Given this list of marker genes DDX11, IVL, KLK7, CEP131 (NCBI Gene Id 22994), H19, SLPI, MYZAP, KRT78, PLBD1, PALMD, RMI2, VSIG10L, MIR1915HG, FAM25A, DEGS2, KRT24, PRRT3-AS1, CEP68, TEDC1, RAPGEFL1, ANPEP, HES5, FAM117A, IGFL1, PLLP, CALML5, WDR62, EPN3, S100A7, CCDC88B, FOXRED2, LRRC45, ECM1, HERC2P2, KLK11, HOPX, BNIPL (BCL2 interacting protein like), KIFC2, NCCRP1, PADI1, CRCT1, ABHD14A, ZNF608, TCN1, CRABP2, TENT5B, HEY1, NGEF, ADAMTSL4, LY6D, ZNF467, PGLYRP4, SOX6, DHRS9, CYSRT1, ARHGEF4, SBSN, EPHA4, RPTN, CWH43, KCP, FAM238C, DDX12P, RHOBTB1, HROB, OSR1, EPB41L3, ALDH3B2, TBC1D8, ANKRD22, TRIM45, RFX2, RCOR2 (REST corepressor 2), TEDC2, SERPINB3, TMEM45B, TMPRSS13, CAPN14, CBX2, DGAT2, PRICKLE2, SULT2B1, SMO, FZD2, ANKRD35, TUBAL3, TMEM184A, LURAP1L, E2F8, KLK13, TGFB3, ZSCAN31 (NCBI Gene Id 91921), RBBP8NL, SPRR1A, CSTA (cystatin A), RNF208, WDR90, EPHB3, TMEM86A, DBP, LCE3D, RHCG, NECTIN4, DDX12B, GUCY1A1, HPGD, NLRX1, PLXNB3, ENSG00000205890, C21orf58, MAB21L4, KLK10, RHOV, RASL11B, EPHX3, SH3BP5-AS1, PPFIBP2, GRHL3, SLC43A2, MIR600HG, ATP6V1E2, LRRC20, ANXA9, CEACAM5, GSEC, CASTOR1, VAV3, S100A9, A2ML1, MUTYH, PHLDB3, CLCA4 (NCBI Gene Id 22802), SCNN1B, SERF2, EFNA4, S100A12, ADM5, SPINK5, CEBPA-DT, CES3, SPRR3, AIF1L, CEBPA (NCBI Gene Id 1050), ZNF862, LINC01559, PLA2G4E, PLA2G6, CSTB, RAP1GAP, SLC25A27, NBEAL2, EVPL, VGLL1, SYT8, KMT5C, EFNA3, RARB, CCDC78, SPINK7, ARHGAP33, ANO8, SYTL1, EFS, IFITM10, KLK8 (kallikrein related peptidase 8), FAM86B3P, ITGB7, LUARIS, CTSV, KALRN, AQP3, TJP3, S100A8, AATBC, PRR15L, MVK, LYNX1, GDPD3, ATP12A, SPRR1B, CARD14, SLC37A2, PPP1R3C, FAM86C1P, ANKRD18A, CHTF18, IRAG2, HYAL1, NOXA1, KRT16, CXXC5, E2F1, EME1, C15orf62, BICDL2, JMJD7, THAP8, CALB1, RASAL1, CNKSR3, MEIS1, MZF1, VWF, PRSS27, CNFN, LYPD3, ZNF692, SIX5, UNC13D, FBF1, LMCD1, COQ8A, KLK12, PLA2G4F, PLEKHH3, MUC21 (mucin 21, cell surface associated), IDI2-AS1, here is a description of the gene set: from publication Blanco-Melo D, Nilsson-Payant BE, Liu WC, Uhl S, Hoagland D, Møller R, Jordan TX, Oishi K, Panis M, Sachs D, Wang TT, Schwartz RE, Lim JK, Albrecht RA, tenOever BR (PMID 32416070) Human Gene Set: BLANCO_MELO_BETA_INTERFERON_TREATED_BRONCHIAL_EPITHELIAL_CELLS_DN studied in species Homo sapiens Genes down-regulated on treatment of normal human bronchial epithelial cells with beta interferon (hIFNB treatment 100u/ml, 4-12hrs). Analysis of the transcriptional response to SARS-CoV-2 compared with other respiratory viruses, including MERS-CoV, SARS-CoV-1 (SARS), human parainfluenza virus 3 (HPIV3), respiratory syncytial virus (RSV), and IAV.